Given this list of marker genes FGF7, FGF2, FGF4, EGF, FGF10, here is a description of the gene set: studied in species Homo sapiens part of: Developmental Cell Lineages of the Exocrine Pancreas Reactome Pathway: Developmental Lineage of Multipotent Pancreatic Progenitor Cells Definitive endoderm forms during gastrulation and then undergoes patterning along anterior/posterior, dorsal/ventral, and median/lateral axes. Definitive endoderm cells produce, among other embryonal cell types, endoderm cells of dorsal and ventral foregut. The dorsal foregut endoderm cells, which transition through an intermediary duodeno-pancreatic endoderm cell state, and the ventral foregut endoderm cells, which possibly transition through a hepato-pancreatic or pancreato-biliary intermediary state, give rise to primary multipotent pancreatic progenitor cells (MPCs) that form dorsal and ventral pancreatic buds, respectively.